The following is a description of a gene set: Host-pathogen interaction of human coronaviruses - MAPK signaling studied in species Homo sapiens Human Gene Set: WP_HOSTPATHOGEN_INTERACTION_OF_HUMAN_CORONAVIRUSES_MAPK_SIGNALING, and this is the list of marker genes: JUN, MAPK8, JUNB, IFITM1, MAP2K6, FOS, MAPK10, MAPK3 (mitogen-activated protein kinase 3), MAP3K4, MAP2K4, MAP3K1, MAP2K1, MAPK12, MAPK13, IFITM2, MAPK1, BCL2, EIF4E, MAP3K11, RPS6KA2, MAPK11, MAP2K2, MAP2K7, RPS6KA1, DDIT3, MAP3K9, MAP3K10, IFITM3, BST2, MAPK9, RAF1, IFI27, RPS6KA3 (NCBI Gene Id 6197), ATF2, MAPK14, MAP2K3